Given this list of marker genes LDB3, MYL3, VCL, SP110, ACTN2, PDGFRA, here is a description of the gene set: Human Gene Set: HP_ENDOCARDIAL_FIBROSIS species: Homo sapiens The presence of excessive connective tissue in the endocardium. Endocardial fibrosis